Given this list of marker genes ITGA4, ITGB7, VCAM1, SELE, ITGB1 (integrin subunit beta 1), ITGB2, SELPLG, ITGA2, ICAM1, MADCAM1, here is a description of the gene set: species: Homo sapiens Vedolizumab therapy for inflammatory bowel disease Human Gene Set: WP_VEDOLIZUMAB_THERAPY_FOR_INFLAMMATORY_BOWEL_DISEASE